Given this list of marker genes Hyal3, Gm2a, Chil3, Naglu, Naga (N-acetyl galactosaminidase, alpha), Hyal1, Hyal4, Hyal2, Spam1, Cemip2, Hexd, Cemip, Hexb, Hyal5, Hexa, Oga, Nagpa, here is a description of the gene set: Mouse Gene Set: GOMF_HEXOSAMINIDASE_ACTIVITY species: Mus musculus Catalysis of the cleavage of hexosamine or N-acetylhexosamine residues (e.g. N-acetylglucosamine) residues from gangliosides or other glycoside oligosaccharides.